Given this list of marker genes AKAP8, RNF26, GPC6, CTCF, PCIF1, ELOVL5, SATB2, DDX17, CIPC (NCBI Gene Id 85457), TRIB2, NR2C2, PPP4R3B, SLIT2, SRSF3, TMEM187, MRPL1, ZNF638, RBM3, KPNA6, CBLN1, NR4A1, SOX14, CKB, CAPRIN1, PTBP1, TRA2B, SFPQ, ILF3, CEP95, NCOA6, CXXC1, NOL4L, DDX5, UBXN11, PELI2, ILF3-DT, MEX3D, CRKL, PRPF38B, ARF1, EIF4G2, YWHAE, FKBP3, ZFX, SLC39A7, SMPD3, PAK4, SREBF2, PUM1, MTMR3, RUNX1T1, MOK, SUMO1, PCF11, UBE4B, BCL2L13, TGFB1I1, CSNK1A1L, HES6, NFYC, PIM2, EP300, RXRB, MED14, here is a description of the gene set: from publication Xie X, Lu J, Kulbokas EJ, Golub TR, Mootha V, Lindblad-Toh K, Lander ES, Kellis M (PMID 15735639) studied in species Homo sapiens Comprehensive identification of all functional elements encoded in the human genome is a fundamental need in biomedical research. Here, we present a comparative analysis of the human, mouse, rat and dog genomes to create a systematic catalogue of common regulatory motifs in promoters and 3' untranslated regions (3' UTRs). The promoter analysis yields 174 candidate motifs, including most previously known transcription-factor binding sites and 105 new motifs. The 3'-UTR analysis yields 106 motifs likely to be involved in post-transcriptional regulation. Nearly one-half are associated with microRNAs (miRNAs), leading to the discovery of many new miRNA genes and their likely target genes. Our results suggest that previous estimates of the number of human miRNA genes were low, and that miRNAs regulate at least 20% of human genes. The overall results provide a systematic view of gene regulation in the human, which will be refined as additional mammalian genomes become available. Human Gene Set: ACAWNRNSRCGG_UNKNOWN Genes having at least one occurrence of the highly conserved motif M103 ACAWNRNSRCGG in the regions spanning 4 kb centered on their transcription starting sites. The motif does not match any known transcription factor binding site.